The following is a description of a gene set: studied in species Homo sapiens Human Gene Set: REACTOME_COOPERATION_OF_PDCL_PHLP1_AND_TRIC_CCT_IN_G_PROTEIN_BETA_FOLDING Cooperation of PDCL (PhLP1) and TRiC/CCT in G-protein beta folding, and this is the list of marker genes: CCT6A, GNG10, GNB5, CCT5, CCT2, CCT8, GNA11, GNB3, GNB2, GNG4, CSNK2A2, GNG12, GNA14, CSNK2B, GNG11 (NCBI Gene Id 2791), GNGT2, TCP1, RGS9, CCT3, CSNK2A1, GNGT1, GNG2, RGS11, GNG13, PDCL, GNB4, RGS6, GNG8, CCT4, CCT6B, GNB1, RGS7, GNG3, GNG5, GNAQ, CCT7, GNG7, GNA15